The following is a description of a gene set: Mouse Gene Set: GOCC_VESICLE_TETHERING_COMPLEX Any protein complex that plays a role in vesicle tethering. studied in species Mus musculus, and this is the list of marker genes: Vps53, Vps54, Cog7, Myrip, Washc1, Trappc10, Cog3 (component of oligomeric golgi complex 3), Exoc3l2, Tnfaip2, Vps33a, Trappc12, Vps52, Exoc6b (exocyst complex component 6B), Hook1 (NCBI Gene Id 77963), Cog5, Exoc5, Cdc42, Exoc6, Cog1, Trappc3, Cog6, Trappc11, Exoc2, Stx17, Vps16, Trappc5, Vps11, Exoc4, Tgfbrap1, Eipr1, Exoc1, Exoc7, Trappc1, Trappc3l, Trappc6a (trafficking protein particle complex 6A), Zw10, Vipas39, Exoc3l4, Sh3bp1, Aktip, Trappc8, Trappc2b, Vps39, Exoc3l, Trappc2l, Trappc2, Exoc8, Rint1, Septin2, Hook3, Trappc14, Tmem115, Nbas (neuroblastoma amplified sequence), Hook2, Cog2, Trappc9, Vps33b, Synpo2, Vps18, Vps41, Grip1, Exoc3, Rab10, Vps51, Cog4, Vps8, Trappc13 (trafficking protein particle complex 13), Trappc6b, Cog8, Trappc4